The following is a description of a gene set: Neighborhood of ACTG1 Human Gene Set: MORF_ACTG1 Neighborhood of ACTG1 actin, gamma 1 in the MORF expression compendium studied in species Homo sapiens, and this is the list of marker genes: RPL13, RACK1, UBC, DAZAP2, SLC25A3, RHOA, RPL10A, NCL, UBE2I, RPL8, EEF1G, RPS11, COX4I1, RPS6, EIF4A2, NAP1L1, JUND, RPS8, FAU, RAN, EIF4A1, RPL29, ZFPL1, EEF2, UBB, HMGN2, YWHAZ, RPS19, ARPC3, BTF3, NPM1, RPL27A, RPS14, RPL27 (NCBI Gene Id 6155), SLC25A6, MAZ (MYC associated zinc finger protein), PCBP2, TUBA1B, COX5B, RPL19, PGK1, TAGLN2, RPL12, SRP14, RPL22, RPL17, CLIC1, RPL28, SUMO3, GNAS (NCBI Gene Id 82944), RPL10, RPS24, RPL23A, RPL14, SSR2, COX6A1, ACTB, RPS17, RPS18, RPL15, RPL31, ACTG1, RPLP2, HSP90AA1 (heat shock protein 90 alpha family class A member 1), RPL37, OAZ1, PTMA, RPS20, RPS23, CFL1, RPL30, RPL18A, RPL36A, PFN1, RPL32, RPS4X, RPS12 (ribosomal protein S12), RPL4, CALM2, HDGF, RPL6, COX7C, PPIA, BTBD2, COX8A, PABPC1, EEF1A1, RPL34, RPS27, RPL18 (NCBI Gene Id 6141), NACA, RPS9, TPT1, RPS13, RPS29, HNRNPC, RPL9, HNRNPA1, RPS10, RPS5, RPL13A, RPS25, HINT1, RPS3A, RPLP0, RPL24, RPL23, MYL6, HSP90AB1, H3-3A, LYPLA2, LDHA, JTB, RPS27A, RPS15A, SNRPB, RPL7, B2M, HNRNPK, RPL5, RPLP1, RBM3, EEF1B2, RPS28, RPS3 (ribosomal protein S3), SUMO2, ARPC2, RPL3, NME2, PSMB1, YBX1, RPL38, RPS16, RPL21, RPS7, ENO1, RPL11, EIF4G2